The following is a description of a gene set: studied in species Homo sapiens A cell cycle arrest process that results in arrest during G1 phase, whereupon the cell enters G0 phase, in the context of cell differentiation. Human Gene Set: GOBP_G1_TO_G0_TRANSITION_INVOLVED_IN_CELL_DIFFERENTIATION, and this is the list of marker genes: SLC39A5, ZNF503, CDK5R1, RNF112, GATA6, CAPN3